Given this list of marker genes UPK1A, KLF5, RAB43, SNAP47, TTBK2, RAB6B, BSN, PLEKHM1, RAB28, LRRC8A, CHST3, RASSF1, RPL7L1, ZNF592, MKRN1, EPHB3, RPRD1B, MED26, LOXL4, PLET1, KIAA0232, TRABD2B, FGFR2, RAPGEF1, LASP1 (LIM and SH3 protein 1), UNC5CL, CAMKV, HDAC6, SRSF7, CBX2, SH3GL1, ZNF608, CCDC85C, ADAP1, LINGO2, FAM168A, MLXIP, FAM180A, AMBP, INO80D, AIFM3, CXCR5, NOL6, CTIF, CLASP2, DPP8, MMP24, ADCY2, TPPP, NGEF, COL26A1, FAXDC2, ZNF335, APBA2, ATP10A, here is a description of the gene set: species: Homo sapiens Human Gene Set: MIR4763_5P Genes predicted to be targets of miRBase v22 microRNA hsa-miR-4763-5p in miRDB v6.0 with MirTarget v4 prediction scores > 80 (high confidence targets). from publication Chen Y, Wang X (PMID 31504780)